The following is a description of a gene set: studied in species Homo sapiens Genes predicted to be targets of miRBase v22 microRNA hsa-miR-205-3p in miRDB v6.0 with MirTarget v4 prediction scores > 80 (high confidence targets). from publication Chen Y, Wang X (PMID 31504780) Human Gene Set: MIR205_3P, and this is the list of marker genes: SERTAD2, PLCL1, TMEM245, TMEM54, SYNRG, POGLUT3, TOX, SEMA3C, WASF1, TTPAL, SCARF1, XIRP2, TMPO, CALML4, CREB1, LRRTM3, NCOA7, DNM3, PCNP, RASSF6, PCNX1, TET2, ATP10D, PRKAA1, ZNF407, TET1, RAB1A, RRM1, LPGAT1, PMEL, PDE1C, MGAT4A, METTL8, TAFA1, ATP8A1, SLC12A2, CHCHD1, CDH11, RASSF2, GOLGA8R, LRRC8B, FZD3, COL10A1, CHST1, HAT1, GDPD1, AZI2, SMCHD1 (structural maintenance of chromosomes flexible hinge domain containing 1), AZIN1, SEC62, CMC1, C8orf58, TP53AIP1, AGFG1, MS4A1, PTTG1IP, ZBTB10, ZBTB33, CEP63, SANBR, LYPLA1, CNIH1, RBBP5, LAMA4, SLC35F4, RER1, RPP14, COL3A1, NEDD9, ANKIB1, MKLN1, RCN2, TMEM132B, UBE2V1, MAPK8, FREM1, POT1, ARHGAP19, CASP1, WAC, HDAC9, SFT2D1, TFCP2L1, IVNS1ABP, BCL7B, ABCA8, FER1L5, MECP2, FAM133A, RGS18, RMC1, USP38, ERAP1 (NCBI Gene Id 51752), ENTPD1, CDC42SE2, GLS, SH3TC2, GPC4 (NCBI Gene Id 2239), SKIC3, NFATC3, HACD1, MOB1B, CRYM, SLC12A1, DMRT1, DYNC1LI1 (dynein cytoplasmic 1 light intermediate chain 1), PNPT1, PALM2AKAP2, NHS, ASB7, PLEKHM3, NRXN1, LACTB, DYNC1I2, WASHC4, MYOC, TRIM33, CSTF2, MEIOC, PIK3CG, PRELID2, SIRT1, NUP54, MNT, URI1, SLC6A14 (solute carrier family 6 member 14), PALS2, ZBTB20, NLGN1, INO80D (NCBI Gene Id 54891), TMED4, RYR3, WBP2, HYCC1, CSGALNACT2, STEAP2, RSBN1, GGH, GOLGA8N, DUSP22, ESYT2, NBEA, TMEM209, ASXL3, B4GALT6, RELCH, NKIRAS1, CERKL, GCLM, ADCY9, NOX4 (NCBI Gene Id 50507), HS3ST2, MSANTD4, NEMP1, CNR1, F5, MMP16, BRWD1, AFTPH, DENND4A (DENN domain containing 4A), MSI2, AAK1, ECPAS, CLK2, TMEM170B, TMEM144, UBE2G1, GOLGA6C, TUT7, SESTD1, VAX2, PABIR1, PPP1R3B, LRRC19, NUS1, MBNL2, TRMT13, FAM120B, CKB, GAS2L3, ARHGAP15, RIPOR3, PIP5K1B, CHMP2B, TRAM2, MBTPS2, RAB10, SH3BGRL2, NYAP2, CCSER1, CARNMT1, TSC22D2, GOLGA8Q, LEPROT, CDH9, LIN9, PCGF1, NUP50, DRG2, DTL, PDZK1IP1, RPRD1A, TMEM237, INTS6, CPPED1, ITGB8, FUT9, CRPPA, CREBZF, SUCNR1, ARID4A, RAB21, ZNF644, INAFM2, USP10, MAP3K4, ALCAM, GPC6, DLD, PLA2G6 (phospholipase A2 group VI), ARL4A, TAB3, ZBTB44, ATRN, KRTAP4-2, PRPF40A (NCBI Gene Id 55660), CCDC59, PANK3, TOMM20, UNC13C, GABRG1, MORC3, NUDT15, SMG1, ERMP1, FBXO34, APAF1, B3GNT2, HOMER1, PMFBP1, TTC33, XYLT1, DUSP16, RBM39, SEL1L, IMPA1, ATPSCKMT, KCNJ13, EDARADD, USP49, CAP2, RAD1, ANKRD12, PAPOLG, SSR3, CACNA1E, RFX3 (NCBI Gene Id 5991), TOPBP1, NUFIP1, TDRKH, DST, GOLGA8M, ATP5PB, ABCC4, ZNF596, PLAC8, TSPAN2, CYRIA, PIAS2, NPM1, SMIM13, SLC30A8, KCNS3, GIPC2, TOB1, ROCK2, MCTP2, GBP1, SH3GL3, ELF2, AP1S1, ZC3H12C, BPNT2, ADGRL2, CPED1, G0S2, CAPN14, GOLGA8J, RNGTT, LZIC, SLC15A2, TFDP2, GLRB, TOX3, OOSP2, RBM4B, C5, TNRC6B, GNAS, ADAM7, CCSER2, MIER3, APC, TIMM8A, TYW3, NOL4, VANGL1, SLC35D3, GOLGA8T, RXFP1 (relaxin family peptide receptor 1), ALG10, LAMP5, ATRX, GKN1, MELK, KIAA1549, C5orf24, CWC27, CILK1, NAA50, RRM2B, ADAM10 (NCBI Gene Id 102), TRIM59, MAML2, HDX, CYSLTR1, HROB, NDST3, SPAG16, CXCL11, ARMC1, ARHGAP12, FGL2, SEMA3A, APBB2, RMDN1, SYT4, CBLN1 (NCBI Gene Id 869), SESN3, C2orf88, TRAPPC14, ATXN1, MAP4 (NCBI Gene Id 4134), C3orf70, KLF12, ACTA2, PPP4R2, ZBED4, MRC1, AMMECR1, CEP350, PRNP, GOLGA8H, MEGF9, ZBTB41, GEMIN2, GRIA2, TFEC, IGF1, RASGRP1, GALNT13, CAP1, PDK4, PAH, COL25A1 (NCBI Gene Id 84570), COBL, GJA1, TBR1, EPB41L4B, IFT57, RAB3GAP2, NEK7, PAG1, MGA, PDIA5, UNC80, CASD1 (CAS1 domain containing 1), RAB30, YWHAB, CXADR, PDLIM5, TBC1D8B, YBX3, SERINC1, ARL1, HECW1, EXOC8 (NCBI Gene Id 149371), NANOS1, PARL, UBE2R2, BCLAF1, DPEP2, CA8, MINDY2, SLC49A4, SLC27A6, LRCH1, ARPP19, DYNLT1, RAB27B, SEPTIN9, PPM1D (NCBI Gene Id 8493), ENAH, TNKS (tankyrase), PAGR1, ECM2, NDFIP1, SLC1A1, PDE10A, ZC2HC1A, BOLA2-SMG1P6, RECK